Given this list of marker genes HCRTR1, NRG1, RTN2, UBLCP1, DPYSL3, SV2C, VDAC2, PHOSPHO1, CROT, MTAP, EBF3, KIF5B, BAIAP3, VWA5B2, ANXA5, CCT8, TSC22D3, GPR101, CD59, CHRNB4, YPEL5, ENDOD1, CAT (catalase), MARCHF2, SLC17A6, KANK4, SLC6A5, ABHD3, TMEM205, MAGED2, KLK6, ANKRD35, FSTL1 (NCBI Gene Id 65385), CYP27A1, ABHD4, TNS1, IMPA2, AKAP12, MRAP2, KCNG4, CD83, GLRA4, ANKRD55, RND2, GLRA2, GABRQ, RASSF4, SGPP2, GET1, DNPEP, ESRRG, LTBP3, PANX2, CALM3, S100B, DLK1 (NCBI Gene Id 8788), PCSK1N, ECE2, NDUFS1, STEAP2, GLRA1, LGALS8, SPP1, EMC9, SLC18A2, HSPB8, HMGA1, COQ7, FAM156A, NDUFB5, CDH23, TMEM176A, EIF5A2, P2RX5, GFAP, HCN2, KCNJ14, HTR2C, RAB37, COPRS, P2RX6, PMP22, AHNAK2, GPC5, ADAMTS2, KCNAB2, CABP7, FAM13A, CAPN1, ENTPD3, B3GALT5, CLGN, here is a description of the gene set: Top 100 ranked genes most specific to pons region (P) of the adult mouse brain. from publication Lein ES, Hawrylycz MJ, Ao N, Ayres M, Bensinger A, Bernard A, Boe AF, Boguski MS, Brockway KS, Byrnes EJ, Chen L, Chen L, Chen TM, Chin MC, Chong J, Crook BE, Czaplinska A, Dang CN, Datta S, Dee NR, Desaki AL, Desta T, Diep E, Dolbeare TA, Donelan MJ, Dong HW, Dougherty JG, Duncan BJ, Ebbert AJ, Eichele G, Estin LK, Faber C, Facer BA, Fields R, Fischer SR, Fliss TP, Frensley C, Gates SN, Glattfelder KJ, Halverson KR, Hart MR, Hohmann JG, Howell MP, Jeung DP, Johnson RA, Karr PT, Kawal R, Kidney JM, Knapik RH, Kuan CL, Lake JH, Laramee AR, Larsen KD, Lau C, Lemon TA, Liang AJ, Liu Y, Luong LT, Michaels J, Morgan JJ, Morgan RJ, Mortrud MT, Mosqueda NF, Ng LL, Ng R, Orta GJ, Overly CC, Pak TH, Parry SE, Pathak SD, Pearson OC, Puchalski RB, Riley ZL, Rockett HR, Rowland SA, Royall JJ, Ruiz MJ, Sarno NR, Schaffnit K, Shapovalova NV, Sivisay T, Slaughterbeck CR, Smith SC, Smith KA, Smith BI, Sodt AJ, Stewart NN, Stumpf KR, Sunkin SM, Sutram M, Tam A, Teemer CD, Thaller C, Thompson CL, Varnam LR, Visel A, Whitlock RM, Wohnoutka PE, Wolkey CK, Wong VY, Wood M, Yaylaoglu MB, Young RC, Youngstrom BL, Yuan XF, Zhang B, Zwingman TA, Jones AR (PMID 17151600) Molecular approaches to understanding the functional circuitry of the nervous system promise new insights into the relationship between genes, brain and behaviour. The cellular diversity of the brain necessitates a cellular resolution approach towards understanding the functional genomics of the nervous system. We describe here an anatomically comprehensive digital atlas containing the expression patterns of approximately genes in the adult mouse brain. Data were generated using automated high-throughput procedures for in situ hybridization and data acquisition, and are publicly accessible online. Newly developed image-based informatics tools allow global genome-scale structural analysis and cross-correlation, as well as identification of regionally enriched genes. Unbiased fine-resolution analysis has identified highly specific cellular markers as well as extensive evidence of cellular heterogeneity not evident in classical neuroanatomical atlases. This highly standardized atlas provides an open, primary data resource for a wide variety of further studies concerning brain organization and function. studied in species Mus musculus Human Gene Set: LEIN_PONS_MARKERS